Given this list of marker genes ALDH1L2, EMCN, GXYLT1, RPGRIP1L (NCBI Gene Id 23322), ASAH1, TGFBR1, RPP25L, AHR, GUF1, GOLGA5, NPHP3, PRSS12, IGF1R, SEPTIN7, RIMOC1, ECRG4, ZBTB26, DMD (dystrophin), TPST2, REPIN1, HOXA7, TRIM6, RDH10, KLF8, NAP1L1, NXPE3, PLAGL2, ESYT2, UTRN, GDF6, PPP1R15B, ELP1, ADRB2, BIN3, CPEB3, PRRG1, LIN28B, RUFY3, NHLRC2 (NHL repeat containing 2), RNF38 (NCBI Gene Id 64796), SLC9A6, CBX5, NBN, MAP3K2, DNA2, ERI2, CBFA2T3, CNPY3, BACH2, RGS16, DISC1, HAUS2, IQCB1, SRSF8, SERPINB8, HAND1, NRG4, CFAP161, HS6ST2, MED10, BMPR1A, HOXB7, CADM2, CYP20A1, TIMM23, STIMATE, KLHL31 (NCBI Gene Id 401265), SPRYD4, XPO7, HOXC8, SORCS1, GATA6, GNG5, PPFIA2, MTERF1 (NCBI Gene Id 7978), ACVR1C, FBXO27, NME6, IL10RB, CEP135, TRIM71, HOXA9, ELMOD2, ZNF281, FBXO42, SNX30, GATM (NCBI Gene Id 65211), STK40, PHTF2, MAP3K7CL, FIGNL2, TDRD6, SEMA3A, LPCAT3, GNB3, ZBTB5, LHX1, OSBPL3, SALL4 (NCBI Gene Id 57167), XRCC5, MDM4, ZNF512B, COIL, FOS, TMEM121B, STX3, TRPM3, SCRT1, ZBTB34, JAZF1, ZFYVE26, ADAMTS8, SMAD6, SLC39A8, TGFB1I1, SEC24D, RBMX (RNA binding motif protein X-linked), ZNF569, SVIL, PBX2, here is a description of the gene set: species: Homo sapiens from publication Chen Y, Wang X (PMID 31504780) Human Gene Set: MIR6831_5P Genes predicted to be targets of miRBase v22 microRNA hsa-miR-6831-5p in miRDB v6.0 with MirTarget v4 prediction scores > 80 (high confidence targets).